Given this list of marker genes CARD17P, PCBD1 (pterin-4 alpha-carbinolamine dehydratase 1), ZNF576, DESI1, KIF1B, TAF7, AFF4, GFPT1, SEL1L, RFT1, HSD17B8, ZNF862, MS4A6A, AAK1, RAVER2, TGFBR1, VANGL2, ITGB8, C21orf91, COQ10A, CDC23, SUSD5, CCAR1, EPHA3, SMIM7, ZNF70, HLA-DQA1, KATNIP, ZNF547, ZNF544, MARCHF6, HCCS, XYLT1, BBX, RORA, FAM120C, BAP1, IRF2, ADRA2B, HIC2, ANGPTL2, ARFGEF3, ZNF670, LRATD2, NFASC, FSHR, NR3C1, METAP1, MANEAL, STEAP4, CDH7, MTFR1L, SEPTIN6, CDH3 (cadherin 3), ORAI2, DCTN4, LRG1, TBC1D16, FPGT, ATP8B1, CYP2E1 (cytochrome P450 family 2 subfamily E member 1), AGO3, RGS16, TSEN34, FAM161B, DCUN1D1, GRM5, VPS26C, FOXN1, TBL1XR1, ADGRG7, PALM, RAB5B, LYN, BAHD1, ZBTB20, FN1, KCNE4, FABP7, NIN, ZMYND12, WDR31, HDGFL3, ETS1, CPEB1, POFUT1, GCK, FAXC, AGAP1, AOPEP, COL6A3, IFT70B, SPOCK1, ARL8B, KPNB1, METTL21A, FSD2, CCNT1, ATOSB, TOMM20, PAX7, B9D1, ICOSLG, PCDHB7, SLC6A11, NECTIN1 (NCBI Gene Id 84853), GDAP1L1, CNDP2, MOB3B, NEMF (NCBI Gene Id 9147), FAM168A, NXPH3, HS3ST3A1 (heparan sulfate-glucosamine 3-sulfotransferase 3A1), PDK3, LHFPL5, GABRA5, KLHL18, TIMP3, CACNA1C, PDE8A, INO80D, GAS7, COPG2, BNC1, C19orf44, PLEKHA5, GGT7, CCDC97, UNG, ARHGEF33, DDX31, CLASP2, SORD, ALG2, MTCL2, N4BP1, ABHD2, NEUROG2, SLC5A3, GABBR2, PMM1, FAM118B, CUL3, SLC7A14, here is a description of the gene set: Human Gene Set: MIR204_3P Genes predicted to be targets of miRBase v22 microRNA hsa-miR-204-3p in miRDB v6.0 with MirTarget v4 prediction scores > 80 (high confidence targets). studied in species Homo sapiens from publication Chen Y, Wang X (PMID 31504780)